Given this list of marker genes Eri1 (NCBI Gene Id 67276), Zfp663, Ntn4, Sema6a, Dock9 (dedicator of cytokinesis 9), Ddx17, Gmfb, Rpa1, Zfp704, Ino80, Krt75, Nr4a2, Vwa8, Mon2, Vasn, Ssh2, Hic2, Arhgap15, Ifnar1, Cdo1, Tgfbr2, Naa50, Zfhx4, Rasa1, Sox9, Lox, Cyyr1, Slc25a36, Socs7, Sirpa, Dusp6 (dual specificity phosphatase 6), Dab2, Gabarapl2, Noxo1, Mdga2, Tex16, Xrn1, Tmem144, Ptgfr, Gabarapl1, Ubd, Tent5d, Kif5c, Rev3l, Abr, Grpel2, Sema3a, Zbtb10, Erf, Pan2 (NCBI Gene Id 71734), Erlin1, Flnb, Usp46, Prdm1, Srgap2, Skp1, Rreb1, Rc3h1, Ctnnbip1, Qser1, Myrf, Ttpa, Rgs7, Asap2, Gatad2a, Rabepk, Plce1, Usp31, Ldlrad3, Actb, Abhd17b, Marchf1 (membrane associated ring-CH-type finger 1), Fam174b, Btg1, Tspan6, Rin2, Pxn, Tm9sf4, Trim2 (NCBI Gene Id 80890), Crkl, Lrif1, Rab14, Myl12a, Zfp189, Psd3 (NCBI Gene Id 80295), 5031439G07Rik, Cabp1, Mtrfr, Casz1, Cbfb, Stam, Lancl3, Nuak1, Onecut2, Net1, Nsun4, Arap2, Rapgef2, Mrtfb, Aco1, Sp4, Mosmo, Fam135a, Pals1, Uba6, Slc16a1, Krtap6-7, Glis1, Naa15, Cntn4, Arf6, Insig1, Adpgk, Camk1d, Ggct, Cacna1d, Ctnnd1, Ppp4r2, Slitrk4, Cachd1, Ivns1abp, Mdfic, Bcr, Snx15, Atxn2, Septin11, Acsl4, Pdcd1lg2, Pcbp4, Ebf3, Itpripl2, Mfsd2a, Polr3g, Glis3, Cdk6, Ddc, Krtap4-25, Slc35f5, Ube2d3, Rasa2, Yes1, Rnf170, Spsb4, Phactr2, Abca1, Epn3, Rtkn, Klhl38, Frrs1, Abcb10, Slc44a3, Smad3, Abracl, Irs1, Srgap1, Ndfip2, Slc39a2, Prkx, Fscn1, Ythdc1, Ythdf2, Csn2, Sun1, Nudt7, Ptpn12, Ap2b1, Tbc1d12, Pi4k2b, Slco1a4, H1f0, Ppp3ca, Magi2, Grb10 (growth factor receptor bound protein 10), Ap1g1, Pmp22, Actg1, Izumo3, Bach2, Naa40, Etaa1, Zcchc4, Snx27, Spop, Ifi44, Pdcd4, Kif21a, Trio, Ogt, Mttp, Mpzl2, Serinc5, Katnbl1, Flrt3, Tmem178, Ccdc25, Ankrd28, Erg, Mtx3, Unc119b (NCBI Gene Id 106896), Urgcp, Twist2 (NCBI Gene Id 13345), Ccn1, Dlgap1, Fkbp3, Mkrn3, Garre1, Epb41l5 (NCBI Gene Id 98492), Dyrk1a, Erbb4, Arpc5, Arhgap21, Kcna4, Smad5, Nufip2 (NCBI Gene Id 78671), Mogs, Fli1, Slc35d1, Cd28, Rbak (NCBI Gene Id 57782), Camk2d, Abhd17c, Pcsk5, Efnb3, Plcl2, Hnrnph2, Nectin3, Slc7a8, Chchd3, Nedd9, Qpctl (NCBI Gene Id 67369), Tagln2, Add3, Usp32, Osbpl1a, Tmem167, Angpt2, Adcyap1, Lnpk, Snx8, Mest, Myo5a, Senp2, Scamp3, Dlc1, Tmod1, Spats2, Cpeb1, Smcr8, Camsap2, Ece1, Zfp110, here is a description of the gene set: studied in species Mus musculus from publication Chen Y, Wang X (PMID 31504780) Mouse Gene Set: MIR_145B Genes predicted to be targets of miRBase v22 microRNA mmu_miR_145b in miRDB v6.0 with MirTarget v4 prediction scores > 80 (high confidence targets).